Given this list of marker genes HPSE, KALRN, CAMK1, CENPA, VWF, CXCL3, PRKAR2B, PDGFB, MOB3C, MMRN1, HBD, SLC44A1, RAB27B, STOM, TSPAN15, CD9, GNAZ, EFNB2, KCNE3, PLEK, ESAM, C2orf88, VCL, PDE3A, CCND1, DMTN, LGALSL, SLFN14, C3orf52, GFI1B, RBPMS2, TMEM40, MYL12A, BANK1, CAVIN2, RUFY1, PPIF, GSN, PDE5A, HEXIM1, F13A1 (NCBI Gene Id 2162), TPM1, LIMS1, GP9, FYB1 (FYN binding protein 1), EXOC3L2, ARHGAP18, ABCC4, FCGR2A, PF4V1, THBS1, CLEC1B, GABRE, TMSB4X, TESC, CA2, PDGFA, CALD1, DNM3, LY6G6F, NEXN, LRRC32, MYLK, TREML1, PDLIM1, CCDC68, ABCC3, GP6, SPTB (spectrin beta, erythrocytic), LTBP1, SELP, CMAS, GP1BA, LY6G6D, NRGN, PROS1, ITGA6, PPBP, ACTN1, CTTN, NID1, FERMT3, BIN2 (bridging integrator 2), ARHGAP6, MFAP3L, CCL5, ITGA2B, CD36, CLU, DAAM1, LCN2, CMTM5, COQ2, RGS18, TUBB1, GRAP2, PBK, PF4, here is a description of the gene set: Human Gene Set: ZHENG_CORD_BLOOD_C1_PUTATIVE_MEGAKARYOCYTE_PROGENITOR studied in species Homo sapiens from publication Zheng S, Papalexi E, Butler A, Stephenson W, Satija R (PMID 29545397)